The following is a description of a gene set: Human Gene Set: REACTOME_HEDGEHOG_LIGAND_BIOGENESIS studied in species Homo sapiens Hedgehog ligand biogenesis, and this is the list of marker genes: PSMA3, SEL1L, ADAM17, PSMD7, NOTUM, PSMC4, PSMD12, IHH, PSMA4, PSMB2, PSMD11, PSMA6, SEM1, PSMC6, PSMD3, PSMD2, PSMA7, DERL2, PSMB3, P4HB, PSMB4, ADRM1, OS9, PSMC1, GPC5, DHH, HHAT, DISP2, PSMD6, ERLEC1, PSMD13, PSMB7, SYVN1, PSMD14, PSMA1, SCUBE2, PSMB1, PSMC2, UBC, PSMB6, RPS27A, VCP, PSMD8 (proteasome 26S subunit, non-ATPase 8), UBB, PSMC3, UBA52, PSMA2, PSMC5, PSMA5, SHH, PSMB5, PSMD1